The following is a description of a gene set: from publication Fehniger TA, Cai SF, Cao X, Bredemeyer AJ, Presti RM, French AR, Ley TJ (PMID 17540585) Human Gene Set: GSE7764_NKCELL_VS_SPLENOCYTE_UP species: Homo sapiens Murine NK cells were compared at rest and following 24 hours of IL-15 stimulation for their mRNA expression profiles on the Affymetrix MOE430_2 microarray platform. Additional comparators included resting bulk splenocytes. Genes up-regulated in comparison of NK cells versus total splenocytes., and this is the list of marker genes: RUNX3, JKAMP, UGDH, KLRC1, ERI2, LPIN1, PREX1, KIFC3, CISD3, ZBTB10, MFSD6, ASCC2, AS3MT, APMAP, NOD1, MBTPS2, KLRG1, CCR2, ARFIP1, IPO11, PTPN4, CDC42EP3, DNMT3A, VEGFC, SEMA4A, RHOC, RUNX2, ZBTB20, FZD5, ATP8B4, ZNRF3, AGTRAP, MGAT5, C5orf22, METRNL, PLSCR4, SP4, NCR1, TNFSF14, CD244, RNF157, CMKLR1, PXYLP1, ARHGAP9 (NCBI Gene Id 84526), MPP7, VPS26B, RAB19, DCTN6, ABCB1, GAB3, WDR37, S1PR5, P2RY14, ARSB, GAN, DAB2IP, FASLG, CNMD, SPRY2, BAIAP3, CXCR3, PIK3CB, MON1B, LEAP2, USP47, CHM, ABCD3, RAP2A, KCTD9, PIM1, YPEL1, TATDN1, TMEM37 (transmembrane protein 37), ELOVL7, CRACDL, GAB2, RAP1GAP2, HAUS3, TTC39C, SYT11 (synaptotagmin 11), FAM81A, SMARCD3, C1orf21, SMAD3, NLRC3, USP20, YES1, RNF121, TMEM35B, ITGAX, TTF1, MUL1, CHPT1, SEMA4C, RNF43, RAPH1, PHF13, SSMEM1, CASP9, TET1, TAF13, MCAM, CAPN2, ABI2, EYA1, CYP24A1, TRIM68, TSPAN5, SNX18, PTGER4, PKP4, IL18R1, CAB39, NKG7, ZFP3 (NCBI Gene Id 7537), CDCA7L (cell division cycle associated 7 like), VSIR, VPS33B, CHSY1, TSHZ3, TCF20, UGCG, IQGAP2, PLOD2 (NCBI Gene Id 5352), BMPR2, GZMB, TIRAP, TULP4, DSP, PTGFR, MAPRE2, GRK5, PDP1, UBASH3B, CD96, OCA2, NCK2, RNF128, TRIP4, PRR5L, OLFM1, STXBP5, ZMAT2, FOSL2, ATP10A, CLDN12, SPO11 (SPO11 initiator of meiotic double strand breaks), LGALSL, FBXO28, CRTAM, PRF1 (NCBI Gene Id 5551), ANKRD50, VPS36, C8orf58, SPACA9, PLEKHF1 (pleckstrin homology and FYVE domain containing 1), ARMCX2, KLRD1, GSTM5, SYTL2, PTPDC1, KHDC1L, KLF6, TM7SF3, ATP1B1, TXK, SLC51A, C14orf28, SMAD1, FKBP10, KLF12, GPSM1 (NCBI Gene Id 94330), PTPRE, ELOVL6, CAMK2N1, AFDN, IL18RAP, GSAP, PHACTR3, SEC24D, TAMALIN, NDNF, KLHL4, CEP164, PLEKHA5, RAB27B, PPM1J, L3MBTL2, ANXA2, STXBP2, GPRIN3 (GPRIN family member 3), MMD, PLSCR1, NIPAL1, SNX33, SLC25A46, HSPA1L, ABTB3, NTNG1, GEM